The following is a description of a gene set: The movement of a mast cell in response to an external stimulus. Mouse Gene Set: GOBP_MAST_CELL_CHEMOTAXIS studied in species Mus musculus, and this is the list of marker genes: Chga (chromogranin A), Ccl11, Pgf, Vegfd, Rac2, Kit, Vegfc, Ccl5, Rac1 (Rac family small GTPase 1), Vegfb, Swap70, Vegfa, Ccr3, Rin3